Given this list of marker genes ABCD1, GDNF, SEMA3D, TYMP, SEMA3C, ECE1, NRTN, ERBB3, ATP7A, RET, EDN3, GATA6, EDNRB, B2M, POLG, ERBB2, STAT3, SMO, SREBF1, C1R, here is a description of the gene set: A hole (perforation) in the wall of the intestine. studied in species Homo sapiens Intestinal perforation Human Gene Set: HP_INTESTINAL_PERFORATION